Given this list of marker genes Lrmda, Thop1, Tmem186, Mdn1, Telo2, Rnaseh2c, Fbl, Trim9, Vars2, Mettl2, Polr1a, Smyd5, Pabpc4, Shmt2, Atrip, Wdr62, Hspbap1, Gemin5, Dus3l, Ttc27, Nrf1, Cinp, Dtymk, Nolc1, Ppan, Nop56, Rps6ka6, Nol8, Qtrt2, Ldb1, Haghl, Myc, Tfpt, Emc8, Ddx49, Zswim3, Med22, Mybbp1a, Sidt1, Rgs12, Pthlh, Slc1a3, Mettl13, Sigmar1, Rps13, Aaas, Zfp800, Pdxk, Alkbh2, Iffo2, Grwd1, 0610010K14Rik, Slco3a1, Trp53, Myef2, Qtrt1, Prss41, Fads2, Gar1, Gtpbp3, Lmnb2, Ppp1r14b, 2810414N06Rik, Tmem141, Wdr4, Srm, Aqr, Zmynd19, Pomt1, Shprh, Kat2a, Arx, Pmf1, Gas8, Gins2, Cct4, Sema3b, Lfng, Zfp940, Tubb2a, Mutyh, Ankrd39, Nme1 (NME/NM23 nucleoside diphosphate kinase 1), Farsb, 1810009J06Rik, Ogfod1, Phgdh, Rassf4, Rpl31, Rad54l, Mapk7, Smarcc1, Pcbp4, Atmin, Adat1, Ntmt1 (N-terminal Xaa-Pro-Lys N-methyltransferase 1), Ccdc86, Pole, Cad, Bid, Zfp444, Fhod1, Dph2, Cabcoco1, Rangrf, Snrpg, Rcc2, Rai14, Bcl11b, Rnf157, Sytl1, Mcm7, Gtse1, Timeless, Atg9b, Aar2, Ctbs, Ogg1, Rrp9, Gnpnat1, Bod1l, Nfs1, Lhpp, Dennd6b, Txnrd3, Gtpbp6, Knop1, Tfip11, Hoxa9, Trmt61a, Ybx3, Sfswap, Snrpf, Mus81 (NCBI Gene Id 71711), Mettl1, Tk1, Nfkb2, Cct7, Mvk, Setd4, Ccdc163, Fzd6, Nelfa, Slc29a2, 4930503L19Rik, Siva1, Zfp2, Bivm, Ascl2, Exosc1, Hes6, Mcm3, Mfsd13a, Gipc1, Acer2, Rnaseh2a, Trdn, Fads3, Txnrd2, Smpd4, Homer1, Nhp2, Sox17, Slc1a4, Nasp, Nceh1, Cdk4, Nsun5, Krtap21-1, Mbd3, Rabep2, Tmpo, Drg2, Pmm1, Ddah1, Slc35b2, Crebbp, Rad23a, Stoml1, Dync2i2, Sapcd2, Axin2, Snx24, Srd5a3, Vars1, Wdr54, Sox4, Ptov1, Cited1, Yju2, Trmt9b, Trp53rkb (transformation related protein 53 regulating kinase B), Zbtb48, Ercc1, Ska1, 1700086O06Rik, Bub1b, Tgif2, Gorasp1, Cdc42bpa, Neurog3, Shmt1, Get1, Dnlz, Ercc4, Zbtb21, Zfp213, Cenpp, Trib1, Lrp8, Map4k4, Nbeal2, Lancl2, Ror2, Vezt, Arhgef12, Mrpl38, Srgap2, Hira, Tnfrsf12a (tumor necrosis factor receptor superfamily, member 12a), Pofut1, Bcl11a, Yae1d1, Dhx58, Ephb2, Osr2, D2hgdh, Zbed3, Usp20, Bmp7, here is a description of the gene set: studied in species Mus musculus Genes up-regulated after Cre-lox knockout of APC in the small intestine that require functional MYC. from publication Sansom OJ, Meniel VS, Muncan V, Phesse TJ, Wilkins JA, Reed KR, Vass JK, Athineos D, Clevers H, Clarke AR (PMID 17377531) Mouse Gene Set: SANSOM_APC_TARGETS_REQUIRE_MYC The APC gene encodes the adenomatous polyposis coli tumour suppressor protein, germline mutation of which characterizes familial adenomatous polyposis (FAP), an autosomal intestinal cancer syndrome. Inactivation of APC is also recognized as the key early event in the development of sporadic colorectal cancers, and its loss results in constitutive activity of the beta-catenin-Tcf4 transcription complex. The proto-oncogene c-MYC has been identified as a target of the Wnt pathway in colorectal cancer cells in vitro, in normal crypts in vivo and in intestinal epithelial cells acutely transformed on in vivo deletion of the APC gene; however, the significance of this is unclear. Therefore, to elucidate the role Myc has in the intestine after Apc loss, we have simultaneously deleted both Apc and Myc in the adult murine small intestine. Here we show that loss of Myc rescued the phenotypes of perturbed differentiation, migration, proliferation and apoptosis, which occur on deletion of Apc. Remarkably, this rescue occurred in the presence of high levels of nuclear beta-catenin. Array analysis revealed that Myc is required for the majority of Wnt target gene activation following Apc loss. These data establish Myc as the critical mediator of the early stages of neoplasia following Apc loss.